The following is a description of a gene set: Mouse Gene Set: GOMF_DIPEPTIDASE_ACTIVITY studied in species Mus musculus Catalysis of the hydrolysis of a dipeptide., and this is the list of marker genes: Cpq, Scrn3, Dpep3, Dpep1, Adam10, Pm20d2, Cndp2, Scrn2, Cndp1, Ace, Mep1a, Scrn1, Adam17, Folh1, Pepd, Naalad2, Dpep2